The following is a description of a gene set: Genital hernia Human Gene Set: HP_GENITAL_HERNIA studied in species Homo sapiens, and this is the list of marker genes: RPS6KA3, ELN, COL5A2, COL1A1, COL3A1, COL5A1, EFEMP1, SMAD3